The following is a description of a gene set: Human Gene Set: WAKASUGI_HAVE_ZNF143_BINDING_SITES species: Homo sapiens Zinc-finger protein 143 (ZNF143) is a human homolog of Xenopus transcriptional activator staf that is involved in selenocystyl tRNA transcription. We previously showed that ZNF143 expression is induced by treatment with DNA-damaging agents and that it preferentially binds to cisplatin-modified DNA. In this study, the potential function of ZNF143 was investigated. ZNF143 was overexpressed in cisplatin-resistant cells. ZNF143 knockdown in prostate cancer caused increased sensitivity for cisplatin, but not for oxaliplatin, etoposide and vincristine. We also showed that ZNF143 is associated with tumor suppressor gene product p73 but not with p53. p73 could stimulate the binding of ZNF143 to both ZNF143 binding site and cisplatin-modified DNA, and modulate the function of ZNF143. We provide a direct evidence that both Rad51 and flap endonuclease-1 are target genes of ZNF143 and overexpressed in cisplatin-resistant cells. Taken together, these experiments demonstrate that an interplay of ZNF143, p73 and ZNF143 target genes is involved in DNA repair gene expression and cisplatin resistance. DNA repair genes whose promoters contain putative ZNF143 binding sites. from publication Wakasugi T, Izumi H, Uchiumi T, Suzuki H, Arao T, Nishio K, Kohno K (PMID 17297437), and this is the list of marker genes: TP53, POLB, MUS81, PRKDC, RECQL4, PMS1, APEX1, XPC, RECQL, POLD1, MSH3, BRCA1, CHEK2, POLK, RAD18, EXO1, TDG, PMS2, MSH5, MSH6, GTF2H4, GTF2H5, POLE, RAD23A, SEM1, DDB1, NEIL2, RAD23B, RAD9A, RAD1, FANCD2, REV3L, ERCC4, FANCB (FA complementation group B), CHEK1, RRM2B, ERCC8, LIG4, FANCL, FANCE, APTX (NCBI Gene Id 94135), MRE11, POLI, REV1, FANCG, NTHL1, RECQL5, ERCC1, TDP1, FEN1, MUTYH, MSH2, UBE2N, MSH4